The following is a description of a gene set: Elevated urinary 3-hydroxybutyric acid An increased amount of 3-hydroxybutyric acid in the urine. species: Homo sapiens Human Gene Set: HP_ELEVATED_URINARY_3_HYDROXYBUTYRIC_ACID, and this is the list of marker genes: CA5A, HMGCS2, ACADM, ALDH6A1, FBXL4, OXCT1